Given this list of marker genes Dock4 (NCBI Gene Id 70756), Kcnq2, Disp2, Baz2a, Cntnap1, Dmac2, Slc16a3, Tcim, Plbd2, Sox11, Syn3, Cobl, Mlec, Klf12, Trdmt1, Tnrc6b, Wnt10b, Atf7, Nlrc5, Zfp954, Nf1, Tada1, Urb2 (URB2 ribosome biogenesis 2 homolog (S. cerevisiae)), Igf2bp1, Stap1, Frk (fyn-related kinase), Pafah2, Cpsf4l, Pde7a, Ino80, Dnah17, Chrm3, Fam193a, Dtymk, Nsun4, Pacs2, Tfcp2l1, Smad1, Rora, Atxn7l3, Ing3, Trim33, Zdhhc5, Tjp1, Gas2l1, Slc4a4, Ccnj, Chst11, Adarb1, Rnf223, Il22ra1, Rwdd4a, Artn, Pramel21 (NCBI Gene Id 279185), Unc13b, Srsf6, Birc2, Tmem47, Tm9sf4, Fgf7, Ank3, Paxbp1, Nsg2, Them7, Dnmt3a, Sec16a, Fam114a2, Chd2, Rnft2, Add1, Rfx7, Hoatz, Upf1, Vapb, Foxo1, Azi2, Frs2, Endod1, here is a description of the gene set: Mouse Gene Set: MIR_370_3P from publication Chen Y, Wang X (PMID 31504780) species: Mus musculus Genes predicted to be targets of miRBase v22 microRNA mmu_miR_370_3p in miRDB v6.0 with MirTarget v4 prediction scores > 80 (high confidence targets).